The following is a description of a gene set: Any process that stops, prevents, or reduces the frequency, rate or extent of endocytosis. Human Gene Set: GOBP_NEGATIVE_REGULATION_OF_ENDOCYTOSIS studied in species Homo sapiens, and this is the list of marker genes: SDCBP, CAV1, MIR205, DYSF, PACSIN1, TLR2, SIRPA, UNC119, MIR181B1, ATG3, PIP4P2, LRPAP1, ANKRD13B, UBQLN2, ARF6, TGFB1, APPL1 (adaptor protein, phosphotyrosine interacting with PH domain and leucine zipper 1), NR1H3, MIR17, EPHA3, RIN3, ANXA2, LGALS3, NR1H2 (nuclear receptor subfamily 1 group H member 2), CSK, PRTN3, ABCA7, SNX3 (sorting nexin 3), CD47, LRRTM1, RUBCN, PACSIN2, PRKD1, RABGEF1, PROM2, SNX33, NEU3, APOC1, HMGB1, B2M, LRSAM1, CD300A, WDR54, PLSCR1, SYT11, FCGR2B, APOC2, RACK1, MIR27B, CNN2, PCSK9, SH3GL3, STX1B, ANKRD13D, ABCA2, APOC3, ADIPOQ, MIR92B, LRRTM2, SCAMP5, CD300LF, LILRB1 (leukocyte immunoglobulin like receptor B1), MCTP1, RAC1, ATXN2, MIR199A1, MTMR2, NECAB2, PACSIN3, PICALM, DLG4, MIR185, ATG5, ANKRD13A